The following is a description of a gene set: studied in species Homo sapiens Human Gene Set: GSE17721_POLYIC_VS_CPG_16H_BMDC_UP mouse primary BMDCs were stimulated with tlr ligands and gene expression changes were profiled on Affymetrix arrays from publication Amit I, Garber M, Chevrier N, Leite AP, Donner Y, Eisenhaure T, Guttman M, Grenier JK, Li W, Zuk O, Schubert LA, Birditt B, Shay T, Goren A, Zhang X, Smith Z, Deering R, McDonald RC, Cabili M, Bernstein BE, Rinn JL, Meissner A, Root DE, Hacohen N, Regev A (PMID 19729616) Genes up-regulated in comparison of dendritic cells (DC) stimulated with poly(I:C) (TLR3 agonist) at 16 h versus DC cells stimulated with CpG DNA (TLR9 agonist) at 16 h., and this is the list of marker genes: SERTAD1, UBE2L6, RGL2, UNK, TRIM25, CD164, BRWD3, ZMYM4, FRYL, TMA16, ASPA (aspartoacylase), FABP3, RSRP1, HNRNPM, PSME2, GPNMB, PLAC8, KLHL11, CDKN1A, ADRA1A, PKDREJ, STAT1, SELENOW, ZNF740, ZNF574, GALNT7, DOP1B, TCTA, ACYP2, RIMOC1, TNFRSF1A, TNFAIP3, TCIRG1, CPXM2, NCOA6, FCGR3A, SBDS, SLC37A1, STAP2, BTBD2, TOP3A, RBM3, RHOC, ADD3, CCDC71L, ARMC10, ALDH1B1, ZBTB17, ZKSCAN3, ZNF212, KRCC1, PRELP, GTPBP6, SPEG, COL12A1, N4BP3, SIRT7, ADAR, TNNI3, BCL2L14, RECK, MSRB1, CTNS, PTK2B (protein tyrosine kinase 2 beta), PLIN2, ASB13, SLC44A1, PPP1R14C, GTPBP1, PDGFD (platelet derived growth factor D), C19orf12, DNASE2B, PHIP, TRIM41, ATP10A, CTCF, AFF1 (NCBI Gene Id 83116), PSEN2 (presenilin 2), SMARCD2, PHGDH, GRINA (glutamate ionotropic receptor NMDA type subunit associated protein 1), IL7R, BCL2L1, MED28, CA6, AKT3, USP15, INPP5D, ANAPC4, BASP1, FBN2, HSD17B2, ATM (NCBI Gene Id 8068), NCOA1, KRTAP19-5, ACVR2A, NRP2, STAB1, B4GALT5, PDCD6, HACL1, PPARGC1B, GNPDA1, GALC, RNF181, CLK3, TBC1D13, AAK1, JPH2, NINJ1, MTM1, F5, ACADL, CRIP3, CIITA, BRD2, EWSR1 (NCBI Gene Id 2130), FAM174B, PPP1R8, CCNL1, CASP3, DENND4C, NDST4, YTHDF1, TXNIP, MX2, PGF, TMEM140, ORM1, PARP12, LMO2, TNRC18, RAB27B, ACTA1, MBD3L1, B3GNT8, CCDC86, SLAMF8, LYL1 (NCBI Gene Id 4066), CCDC6, TRAF7, HOMER1, CEP250 (centrosomal protein 250), POP7, TDRD7, WDR43, SHARPIN, TP53I13, ATP8A1, EPPK1, TAC3, HSF2, ASCC1, APOBEC3B (NCBI Gene Id 9582), PDCD1, SH3BP2, ZNF318, DMTF1, LYZL4, EXOC6, RASA4 (NCBI Gene Id 10156), CTNNA1, GJC2, ASB3, SLC30A7, ZYX, HS3ST1, IRF2, ARHGAP10, ZNF347, LRP4, KATNA1, FXYD5, TOB2, TRIM34, TRIP12, GPSM2, EBF3, XK, C8orf33, SLC3A2, KCTD10, RBM43, SYVN1 (NCBI Gene Id 84447), ELF1, ARC, SYNPR, PRRX1, TOR2A, LRRC41, SERPIND1, ATAD1, NSG2, SURF1, MPP1, ESS2, WASHC3, SLC22A23, TEX101, NFIL3